The following is a description of a gene set: Decreased vertical distance from the vermilion border of the lower lip to the inferior-most point of the chin. Short chin Human Gene Set: HP_SHORT_CHIN studied in species Homo sapiens, and this is the list of marker genes: PIK3R1, SLF2, CDK10, VAC14, EDA, FIG4, DDR2, PTF1A, GRB10, COL9A2, ITCH, NFIA, AHDC1, ASXL3, MEF2C (myocyte enhancer factor 2C), SCUBE3, ALG13, MBD5, PTEN, ZBTB24, COA6, SMC3, COX7B (cytochrome c oxidase subunit 7B), FBXO31, NSD2, NSUN2, EBF3, XRCC4, EXTL3, ALDH1A2, ZMPSTE24, RNU4-2, TAF4, RNF13, IGF2, MYOD1, PIGS (NCBI Gene Id 94005), SHANK3, PPP1R21 (NCBI Gene Id 129285), PARS2, MED12, NRCAM, SLC26A2, RECQL4, NDUFS4, TRIO, H19, LMNA, ARID1B, ERCC4, BMPR1A, AP1S2, ADNP, MTOR, MAN1B1, ERCC6, PRKDC, SOX11, FLNA, ERCC8, CAMK2B, ZNF292, SET, ERCC1, CTCF, DST, MAP3K7, ABL1, FBXL4, PAPPA2, CYP26C1, RNU4ATAC